Given this list of marker genes Mir125b-2, Hyal3, Traf2, Ankrd1, Slc2a4, Zc3h12a, Map3k7, Akt1, Adamts13, Ext1, Gpd1, Cfl1, Ikbip, Fabp4, Tnfrsf17, Tnfrsf4, Ccdc3, Tnfrsf13c, Mir690, Cib1, Pias3, Chi3l1, Rora, Tnfrsf11b, Dcstamp, Adam10, Ccl5, Mapk1, Rela, Cactin, Peli3, Txndc17, Nfe2l2, Cldn1, Ikbkb, Mir221, Ccl2, Hipk1, Prpf8, Pycard, Brca1 (NCBI Gene Id 12189), Map2k7, Naip2, Stat1, Fos, Card14, Zfp36l2, Hyal2, Nkx3-1, Chuk, Abcb1a, Erbin, Nr1d1, Tnfsf18, Krt8, Adipoq, Hspa1b, Adamts12, Syk, Ube2k, Sharpin, Ilk, Kat2a, Ocstamp, Rps3, Tmc8, Mir494, Traf3, Ripk1, Mir103-1, Ikbkg, Tank, Zfp36, Smpd4, Prkn, Hyal1, Ptpn2, Ptk2b (NCBI Gene Id 211703), Plvap, Rbck1, Map4k3, Eed, Cxcl16, Commd7, Cldn18, Gbp3, Cebpa, Nr1h4, Rack1, Cd14, Naip6, Spata2, Crhbp, Eda2r, Tuba1a, Cyld, Dbn1, Tnfrsf1a, Slc22a21, Trpv1, Rps6kb1, Pck1, Traf1, Trp53 (transformation related protein 53), Col1a1 (collagen, type I, alpha 1), Birc3, Mir467b, Ythdc2, Ctsk, Casp1 (caspase 1), Nfkb1, Adam9, Dhx9 (DExH-box helicase 9), Mir331, Gsdme, Postn, Camp, Gfer, Ggt1, Otulin, Mmp8, Krt18, Mir1934, Ubd, Cx3cl1, Tnf, Sfrp1, Cyp1b1, Tnfsf11, Umod, Gch1, Wfdc21, Adamts7, Mir695, Edn1, Mir467f, Mir148a, Mir1195, Mir101b, Nfkbia, Mapk3, Ybx3, Gas6, Mapk14, Mir146b, Zfand6, Dab2ip, Casp8 (caspase 8), Tnfrsf11a, Cx3cr1, Has2, H2bc21, Irf1, St18, Actr3, Zfp36l1, Apoa1, Cd70, Tnfsf13b, Kcnj11, Ppp2cb, Gata3, Mir103-2, Lims1, Nmnat3, F2rl1, Traf3ip2, Ptgs2, Rnf31, Tnfrsf1b, Hes1, Tjp2, Nol3, Mir378a, Tradd, Birc2, Pid1, Nkiras2, Sirt1, Dicer1, Nkiras1, Endog, Map3k5, Naip1, Mir222, Asah1, Pias4, Sgms1, Gba1, Insr, Nsmaf, Tnfrsf21, Smpd3, Naip5, Npnt, Gps2, Nos2, Mir125b-1, Myod1, Aff3, Birc7, Smpd1, Akap12, Foxo3, Aim2, Il6, Cdip1, Laptm5, Adam17, Bag4, Traip, Mir143, Tmsb4x, Wdr35, Sphk1, Acod1, Klf2, Ass1, Actn4, Rffl, Myog, Xiap, Trim32, Slc22a5, Gper1, Cpne1, Rraga, Jak2, Tifa, Inpp5k, Tnfrsf18, here is a description of the gene set: studied in species Mus musculus Any process that results in a change in state or activity of a cell or an organism (in terms of movement, secretion, enzyme production, gene expression, etc.) as a result of a tumor necrosis factor stimulus. Mouse Gene Set: GOBP_RESPONSE_TO_TUMOR_NECROSIS_FACTOR